Given this list of marker genes THEM5, TAFAZZIN, LCLAT1, PLA2G6, HADHA (NCBI Gene Id 3030), here is a description of the gene set: Human Gene Set: GOBP_CARDIOLIPIN_ACYL_CHAIN_REMODELING Remodeling the acyl chains of premature (de novo synthesized) cardiolipin (1,3-bis(3-phosphatidyl)glycerol), through sequential deacylation and re-acylation reactions, to generate mature cardiolipin containing high-levels of unsaturated fatty acids. species: Homo sapiens